Given this list of marker genes RHO, GNB3, SLC6A6, SLC24A1, RPGRIP1, CNGA3, PCYT1A, GRK1, PROM1, COL2A1, ALDH3A2, CFAP418, CNGB3, GPR179, LAMA1, HLA-A, CYP4V2, LRIT3, CACNA2D4, CABP4, KIF3B, CACNA1F, PRPH2, POMGNT1, PDE6B, ABCA4, NYX, GNAT1, ELOVL4 (ELOVL fatty acid elongase 4), TRPM1, SAG, GRM6, RIMS2, here is a description of the gene set: Retinal thinning studied in species Homo sapiens Reduced anteroposterior thickness of the retina. This phenotype can be appreciated by retinal optical coherence tomography (OCT). Human Gene Set: HP_RETINAL_THINNING